Given this list of marker genes AK4, ATPAF1, APRT, CSNK2B, EZH2, EIF2S1 (eukaryotic translation initiation factor 2 subunit alpha), SERBP1, CYB5R1, HSPA4L, ATL3, NONO, NPM1, RAB33A, DGKG, THNSL1, DCAF12, AEBP1, CERS2, NUBP1, NMT1, AMPD2, FAM162A, NDUFS7, WDR43, NEPRO, TELO2, UBE2Q2, NUCKS1, TMEM41A, AGPAT5, TXN2, HCFC1, SNX9, COASY, AP1S3, LDHA, RNPS1, TCF19, IPO9, CBX5, TXNDC9, ZWINT (NCBI Gene Id 11130), PPP1R11, FANCG, HSPD1 (NCBI Gene Id 56733), GUCY1A1, RFC5, GOLPH3L (NCBI Gene Id 94793), NOL7, HMGXB4, NARS1, SMC2, MED14, CHCHD4, MED24, NUP43 (NCBI Gene Id 79700), ALG3, FUBP3, TDP1, ENO2, IPO5, MRPL10, ILF3, TOMM6, NDUFB2, UBXN2A (NCBI Gene Id 165324), KPNA3, H2BC3, SDHC, DCAKD, PDXK (pyridoxal kinase), SF3A1, NOLC1, THAP12 (THAP domain containing 12), METAP1, WDR77, POLD3, NDUFAF2 (NCBI Gene Id 91942), SNRPE, LIPT2, MTX2, B3GNT2, MCU, TADA3, ANP32B, POLR1B, TXN, SLC16A10, LPGAT1, POLR1D, TGS1, LRATD1, ARFIP2, GNL3, PMPCB, PABPC4, APBA3, PRIM2, NFE2L1, CASP2, STAP1, TOP2A, SMYD5, AP1G1, PTMA, LSM10, MRPS17, RNF216, RAD23B, SF3B3, ADK, MYC, DNMT1, TRIM59, VEGFA, CSTF3, SUMO2, RAD54B, GSTT1, KHSRP, TLCD1, INTS3, BCS1L, PDXP, MECR, CCDC63, PRDX3, CD5, DPH2, POLE2, DSC1, ST6GALNAC4, DHDDS, RASGEF1A, TARBP1, RPIA, PIM2, OGFOD1, SKP2, SNRPB, ANKRD52, ASF1B, ERLIN2, GPM6B, DDX21, EIF3L, ENDOD1, ALAD, DCTD, GRWD1, MTHFD2, CILK1, DARS1 (aspartyl-tRNA synthetase 1), ACOT9, NDUFAF4, SELENOI, POLH, EIF4EBP1, PSMB3, NUDT19, DDX18, IDH3B, CTH, NSMF, WDR12, BCKDK, CD200, DGCR8, UBIAD1, MIF4GD, OLA1 (Obg like ATPase 1), NDFIP1, DDX39A, MUS81, YBX3, MYO19, here is a description of the gene set: Genes up-regulated in centroblasts versus centrocytes. from publication Caron G, Le Gallou S, Lamy T, Tarte K, Fest T (PMID 19494283) Functional discrimination between normal centroblast and centrocyte obtained from human inflamed tonsils after cell sorting. We used microarrays to detail the segregation between these two B cell subsets Human Gene Set: GSE15271_CXCR4_POS_VS_NEG_GC_BCELL_UP studied in species Homo sapiens